The following is a description of a gene set: Human Gene Set: GOCC_BARR_BODY A structure found in a female mammalian cell containing an unpaired X chromosome that has become densely heterochromatic, silenced and localized at the nuclear periphery. studied in species Homo sapiens, and this is the list of marker genes: MACROH2A2, H2AZ1, FIRRE, LRIF1, H3-3B, SMCHD1, MACROH2A1, H3-3A